The following is a description of a gene set: species: Homo sapiens Human Gene Set: GOMF_INTRAMOLECULAR_PHOSPHOTRANSFERASE_ACTIVITY Catalysis of the transfer of a phosphate group from one position to another within a single molecule., and this is the list of marker genes: PGM1, PMM1, PGAM4, PGM2, PGM2L1, PGAM2, PGM3 (phosphoglucomutase 3), PMM2, PGAM1, BPGM, PGM5